Given this list of marker genes STAT3, NPC1, TRIM27, FOXK1, FEZ2, SLC7A5, MIR199A1, TAB2, KIF25, RNF5, TREM2, EIF4G3, PPTC7, DAP, EIF4G2, RRAGC, BCL2, WDR6, NUPR1, ZKSCAN3, BMF, HMOX1, WASHC1, GOLGA2, HTRA2, HERC1, MET, PIK3CA, EIF4E, WNK1, SIRT2, MTM1, HGF, POLDIP2, UBQLN4, TAB3, BCL2L1, RRAGB, SCFD1, TMEM39A, RUBCN, MAGEA3, EIF4G1, FBXL4, PINK1, USP30, LZTS1, MTOR, IL10, CPTP, EP300, FOXK2, STK38L, RBX1, ERFE, TIGAR, QSOX1, DAPL1, PHF23, RRAGA, MCL1, RASIP1, SMCR8, NRBP2, VHL, SNCA, RPTOR, KDM4A, RNF41, SNRNP70, FEZ1, IL10RA (NCBI Gene Id 3587), CLEC16A, TSC2, LYPLA1, RRAGD, MTMR8, GATA4, KLHL22, AKT1, TBC1D14, MAGEA6, LEP, MLST8, CTSA, VPS13C, TP53, EHMT2, HDAC6, BECN1, TSC1, SEC22B, TSPO, MTMR9, USP36, PTPN22, LEPR, TLK2, ADRA1A, LRRK2, here is a description of the gene set: Human Gene Set: GOBP_NEGATIVE_REGULATION_OF_AUTOPHAGY Any process that stops, prevents, or reduces the frequency, rate or extent of autophagy. Autophagy is the process in which cells digest parts of their own cytoplasm. studied in species Homo sapiens